The following is a description of a gene set: studied in species Homo sapiens Human Gene Set: WP_HALLMARK_OF_CANCER_METASTASIS_AND_EPITHELIALTOMESENCHYMAL_TRANSITION Hallmark of cancer: metastasis and epithelial-to-mesenchymal transition, and this is the list of marker genes: ELF3, SNAI2, GSC2, ELF5, KLF8, SIX1, SUZ12, SIRT1, GRHL2, TGFB1, SNAI1, EZH2, SUV39H1, CDH1, FOXC2, ZEB2, TWIST1, ZEB1, HDAC1, PRRX1, KDM1A, TCF4, HDAC2